The following is a description of a gene set: studied in species Homo sapiens Regulation of MITF-M-dependent genes involved in extracellular matrix, focal adhesion and epithelial-to-mesenchymal transition Human Gene Set: REACTOME_REGULATION_OF_MITF_M_DEPENDENT_GENES_INVOLVED_IN_EXTRACELLULAR_MATRIX_FOCAL_ADHESION_AND_EPITHELIAL_TO_MESENCHYMAL_TRANSITION, and this is the list of marker genes: ITGA2, PXN, ZEB1, GXYLT2, SERPINE1, MITF (NCBI Gene Id 7487), CDH2, STT3B, CDH1, PXDN, SOX2, EDIL3